The following is a description of a gene set: IL-10 or IL-6 stimulation of control 129xC57BL/6 murine bone marrow derived macrophages in the presence of LPS. We used microarrays to detail the global programme of gene expression changes in response to IL-6 or IL-10 stimulation in the presence of lipopolysaccharide. BMDMs were isolated from control, IL-6-/-, and IL-10-/- mice on a 129XBL/6 mixed background mice and differentiated in the presence of CSF-1 for 6-7 days. Cells were scraped and plated in 6 well plates at 2x10e6/well. Cells were washed with complete DMEM and rested for 1-2 hr before stimulation with combinations of IL-10 (10 ng/ml), IL-6 (2 ng/ml) or LPS (100 ng/ml) for 45 min or 180 mins. Complete biological replicates were performed. Genes up-regulated in bone marrow-derived macrophages with IL10 knockout and 45 min stimulation by: LPS versus IL6 and LPS. from publication El Kasmi KC, Holst J, Coffre M, Mielke L, de Pauw A, Lhocine N, Smith AM, Rutschman R, Kaushal D, Shen Y, Suda T, Donnelly RP, Myers MG Jr, Alexander W, Vignali DA, Watowich SS, Ernst M, Hilton DJ, Murray PJ (PMID 17114459) studied in species Homo sapiens Human Gene Set: GSE5589_LPS_VS_LPS_AND_IL6_STIM_IL10_KO_MACROPHAGE_45MIN_UP, and this is the list of marker genes: ZSCAN10, TIE1, ATP6V1F, CRYBB3, SPINK4, DCDC2B, MCHR1, SNX27, XRN2, RPS27, MMD2, COX15, USP45, CLCC1, PSMA1, SSTR5, SHROOM1, HIVEP2, ADH1C, PEX6, IDO1, SLC22A2, GUCY2C, PRSS46P (NCBI Gene Id 729280), GCM1, HEBP1, ALDH3A1, PAQR6, KCNJ3, ZNF202, SLC28A3, TBX20, SLC1A6, CIB3, PXMP4 (peroxisomal membrane protein 4), STAB2, TTLL9, RPL39, SHFL, OTULINL, TPD52L2, CCNDBP1, CETN2, DNM2, SCGN, MAMLD1, MTMR6, C1QA, ACP5, UCP1, DIRAS2, CNGB3, ADCY9, ST8SIA3, RASGRP2, CALB1, TNK1, UBQLN2, NMRK2, TWF2, EIF1, NR1H3, NR2E1, APOL2, SVOP, FEZF1, TMCO6, CLNK, LIPG, ENY2 (ENY2 transcription and export complex 2 subunit), SLC35A2, NKAPD1, SLC1A7, RAB29, PLCH2, XIRP1, LRRN1, SLC37A2, IL12B (NCBI Gene Id 7907), BCO2, HBG2, FBXO32, PTPN5, ZBTB49, SDK2, EGFL8, KLK12, WNK3, SPATA21, PLEKHG5, GLUL, LYPD8, AQP6, DSC3, SP6 (NCBI Gene Id 80320), CFAP54, HAND2, SRP14, KBTBD3, HNRNPUL1, CLEC1B (NCBI Gene Id 51266), SLCO2B1, D2HGDH, CHRNA9, API5, LONP2, ECH1, VTN, TCL1A, MMEL1, SUPT3H, RPS5, DUS2, ZMAT4 (NCBI Gene Id 79698), CR1L, LRRC46, CAPZA1, ETHE1, LRRC39 (NCBI Gene Id 127495), MARVELD3, KRT4, GGT5, SOX1, ASB16, AP5S1, RIBC2, PCNX2, NSA2, TSPAN15, TMEM242, FGF1, SLC22A13, PTGDR, BRAT1, ASB4, UPK1B, PHAX, NAV3, TAOK3, SLC18A1, PPT2, SEMA3E, ING4, RB1, PPP1R15B, SHISA9, SCN11A, ANP32A, FRMD5, ATP5IF1, TACR2, BLTP3B, SUGT1, HMOX2, ACAA2, PLEKHO1, KLRC1, RIMBP2, ADAM22, FGF19, GARIN2 (NCBI Gene Id 161142), DNAJC4, OTX1, ADAP2, SPEG, SLC14A2, LRRC19, FREM1, TOGARAM2, GLB1L3, GNG3, DACH2, SMYD1, SEMA4B, SSU72, ANKRD13D, F7, ALB, BFSP1, APC2, BVES, SSTR2, FGFR4, GLRX3, MDH1, ATP13A4, SCRT2, SYNE4, OAZ1, RBM6, DLL1, MYOM1, SON, CYP3A4, MPPED1, SRI, WASHC3, BARX1, CEL